Given this list of marker genes Cav1, Peli1 (pellino 1), Fzd9, Map3k7, Casp8, Slc25a4, Fadd, Mutyh, Cflar, Nol3, Spata2, Ripk1, Rbck1, Nupr1, Bok, Adprs, Aifm1, Birc3, Trp53, Asah1, Birc2, Parp1, Casp6, Ripk3, Tspo, Zbp1, Cyld, Rnf31, Ybx3, here is a description of the gene set: Mouse Gene Set: GOBP_REGULATION_OF_PROGRAMMED_NECROTIC_CELL_DEATH Any process that modulates the frequency, rate or extent of programmed necrotic cell death. species: Mus musculus